Given this list of marker genes Ogfr, Tacr1, F2rl2, Mc1r, Vipr2, Agtrap, Galr1, Galr2, Crcp, Cckbr, Npy2r, Oprm1, Gcgr, Gpr165, Avpr1b, Oprk1, Uts2r, Fpr2, Cckar, Gpr83, Nmur2, Mc2r, Rxfp3, Mc4r, Cysltr2, Kiss1r, Ntsr2, Hcrtr2, Gpr182, Nlrp6, Ramp3, Ltb4r1 (leukotriene B4 receptor 1), Lhcgr, Gpr84, Vipr1, Fpr1, Gucy2g, Gal, Gpr139, Crhr1, Tshr, Ednra, Npr2, Pth2r (parathyroid hormone 2 receptor), Rxfp4, Gipr, Fpr-rs7, Fpr3, Grpr, Ltb4r2, Ramp2, Gucy2f, Gprc6a, Fpr-rs4 (formyl peptide receptor, related sequence 4, NCBI Gene Id 14291), Ghrhr, Hcrtr1, Gpr171, Mas1, Npr3, Tacr3, Mc5r, Crhr2, Rxfp2, Bdkrb2, Nmbr, Gpr37, Sstr3, Nmur1, Npr1, Pth1r, Oprl1, Fpr-rs3, Sstr5, F2rl1, Mrgpra4, Brs3, Ogfrl1, Agtr2, Glp1r, Tacr2, Gucy2d, Agtr1a, Npy4r, Npsr1, Npy1r, Npffr2, Ednrb, Adcyap1r1 (adenylate cyclase activating polypeptide 1 receptor 1), Avpr1a, Calcr, Oprd1, Gucy2c, Calcrl, Sctr, Gpr37l1, Galr3, Gpr143, Prokr2, Npy5r, Npy6r, Glp2r, Bdkrb1 (bradykinin receptor, beta 1), F2r, Oxtr, Mc3r, Prokr1 (NCBI Gene Id 58182), F2rl3, Fpr-rs6, Mrgprd, Inpp5k, Rxfp1, Agtr1b, Sstr1, Ntsr1, Qrfpr, Prlhr, Fshr, S1pr2, Npbwr1, Mrgprh, Gucy2e, Sstr4, Cysltr1, Ramp1, Sstr2, Aplnr, Avpr2, Mrgpra1, here is a description of the gene set: Combining with an extracellular or intracellular peptide to initiate a change in cell activity. Mouse Gene Set: GOMF_PEPTIDE_RECEPTOR_ACTIVITY species: Mus musculus